Given this list of marker genes ADRA1A, BPIFC, MPZ, PGR, PAGE4 (PAGE family member 4), PRDM10, ZC3H7B, SPRY4, RBM25, ATAD5, SYK, PECAM1, UBR3, NPAT, ZFP69, HTR2C (5-hydroxytryptamine receptor 2C), DNAJC9, NKIRAS1, ADAT2, RRM2, SLCO4C1, PSIP1, AREL1, EP400, TRA2B, ACAD11 (acyl-CoA dehydrogenase family member 11), ARMCX4, ANKRA2, EPHA7, CTNNB1, HMBOX1, SESN2, PAXBP1, ATG14, here is a description of the gene set: Human Gene Set: MIR6816_3P from publication Chen Y, Wang X (PMID 31504780) studied in species Homo sapiens Genes predicted to be targets of miRBase v22 microRNA hsa-miR-6816-3p in miRDB v6.0 with MirTarget v4 prediction scores > 80 (high confidence targets).